The following is a description of a gene set: from publication Qi CF, Zhou JX, Lee CH, Naghashfar Z, Xiang S, Kovalchuk AL, Fredrickson TN, Hartley JW, Roopenian DC, Davidson WF, Janz S, Morse HC 3rd (PMID 17363561) species: Mus musculus We have compared histologic features and gene expression profiles of newly identified plasmacytomas from NFS.V(+) congenic mice with plasmacytomas of IL6 transgenic, Fasl mutant, and SJL-beta2M(-/-) mice. NFS.V(+) tumors comprised an overlapping morphologic spectrum of high-grade/anaplastic, intermediate-grade/plasmablastic, and low-grade/plasmacytic cases with similarities to subsets of human multiple myeloma and plasmacytoma. Microarray and immunohistochemical analyses of genes expressed by the most prevalent tumors, plasmablastic plasmacytomas, showed them to be most closely related to immunoblastic lymphomas, less so to plasmacytomas of Fasl mutant and SJL mice, and least to plasmacytic plasmacytomas of IL6 transgenic mice. Plasmablastic tumors seemed to develop in an inflammatory environment associated with gene signatures of T cells, natural killer cells, and macrophages not seen with plasmacytic plasmacytomas. Plasmablastic plasmacytomas from NFS.V(+) and SJL-beta2M(-/-) mice did not have structural alterations in Myc or T(12;15) translocations and did not express Myc at high levels, regular features of transgenic and pristane-induced plasmacytomas. These findings imply that, as for human multiple myeloma, Myc-independent routes of transformation contribute to the pathogenesis of these tumors. These findings suggest that plasma cell neoplasms of mice and humans exhibit similar degrees of complexity. Mouse plasmacytomas, previously considered to be homogeneous, may thus be as diverse as their human counterparts with respect to oncogenic mechanisms of plasma cell transformation. Selecting specific types of mouse plasmacytomas that relate most closely to subtypes of human multiple myeloma may provide new opportunities for preclinical testing of drugs for treatment of the human disease. Down-regulated genes that best disciminate plasmablastic plasmacytoma from plasmacytic plasmacytoma tumors. Human Gene Set: QI_PLASMACYTOMA_DN, and this is the list of marker genes: BLNK, DUSP22, CCL11, EPAS1, AEBP1, NOL3, GANAB, TIMP1, EXTL2, IPO4, ST14, DDOST, SVIL, COL1A1, ARFIP2, UBE2T, LYVE1, BSG, RGSL1 (regulator of G protein signaling like 1), LZTR1, TBRG4, XBP1, RABGGTA, COL4A2, SENP2, MMP2, MAGED1, BASP1, KAT2A, NECTIN4, EEF1A2, SEC63, SLPI, CALU, CHST1, CTSW, P4HB, PVR, NOL8, CILK1, MYC, ITGB5, GNE, LOXL4, SEC61A1, C1QBP, MYH14 (myosin heavy chain 14), LYPD3, SND1, LAMC2, FARP2, CLIP1, AGR2, STT3A, BMP1, MED29, PIGK, SPON1, DNAJB11, AJUBA, P4HA2, ARHGAP8, SKIL, PARK7, WASL, VEGFA, PSMB3, LAMB1, PDGFRA, INHBB, MAGEH1, LBP, MYBBP1A, STAT2, UCHL5, IGFBP3, MFAP2, EIF4A1, ETV4, RNF25, PTGIS, CSNK1E, COL5A2, USF1, ENPEP, FIGLA, COL6A2, EPCAM, MATK, TRIP6, PPP2R5A, ALPL, TRIB1, FSTL1, SRP9, PRMT7, SPARCL1, CYTIP